The following is a description of a gene set: The orderly movement of a cell from one site to another that will contribute to the progression of the kidney over time, from its formation to the mature organ. species: Mus musculus Mouse Gene Set: GOBP_CELL_MIGRATION_INVOLVED_IN_KIDNEY_DEVELOPMENT, and this is the list of marker genes: Adipoq, Vangl2, Gdf6, Pdgfrb, Pdgfa, Pdgfb